Given this list of marker genes Gata6, Eomes, Hoxa11, Gata6os, Sox2, Actb, here is a description of the gene set: Genes containing one or more binding sites for (Bcl11a) in their promoter regions (TSS -1000,+100 bp) as identified by GTRD version 20.06 ChIP-seq harmonization. species: Mus musculus from publication Yevshin I, Sharipov R, Kolmykov S, Kondrakhin Y, Kolpakov F (PMID 30445619) Mouse Gene Set: BCL11A_TARGET_GENES